Given this list of marker genes Racgap1 (NCBI Gene Id 26934), Tuba1c, Kif20a, Kif1b, Kif18b, Tuba1b, Tubb2b, Klc4, Kif26a, Kif9, Tuba8, Kif5b, Klc3, Tuba3b, Kif12 (NCBI Gene Id 16552), Tuba4a (NCBI Gene Id 22145), Kif21a, Kif3c, Tubb4a, Cenpe, Kif2c, Tuba1a, Tubal3, Kif2b, Tubb6 (NCBI Gene Id 67951), Kif27, Tubb4b, Kifap3, here is a description of the gene set: Reactome Pathway: Kinesins species: Mus musculus part of: Factors involved in megakaryocyte development and platelet production This event has been computationally inferred from an event that has been demonstrated in another species.<p>The inference is based on the homology mapping from PANTHER. Briefly, reactions for which all involved PhysicalEntities (in input, output and catalyst) have a mapped orthologue/paralogue (for complexes at least 75% of components must have a mapping) are inferred to the other species. electronically inferred by orthology from the curated human pathway